The following is a description of a gene set: Top 100 ranked genes most specific to midbrain region of adult mouse brain. from publication Lein ES, Hawrylycz MJ, Ao N, Ayres M, Bensinger A, Bernard A, Boe AF, Boguski MS, Brockway KS, Byrnes EJ, Chen L, Chen L, Chen TM, Chin MC, Chong J, Crook BE, Czaplinska A, Dang CN, Datta S, Dee NR, Desaki AL, Desta T, Diep E, Dolbeare TA, Donelan MJ, Dong HW, Dougherty JG, Duncan BJ, Ebbert AJ, Eichele G, Estin LK, Faber C, Facer BA, Fields R, Fischer SR, Fliss TP, Frensley C, Gates SN, Glattfelder KJ, Halverson KR, Hart MR, Hohmann JG, Howell MP, Jeung DP, Johnson RA, Karr PT, Kawal R, Kidney JM, Knapik RH, Kuan CL, Lake JH, Laramee AR, Larsen KD, Lau C, Lemon TA, Liang AJ, Liu Y, Luong LT, Michaels J, Morgan JJ, Morgan RJ, Mortrud MT, Mosqueda NF, Ng LL, Ng R, Orta GJ, Overly CC, Pak TH, Parry SE, Pathak SD, Pearson OC, Puchalski RB, Riley ZL, Rockett HR, Rowland SA, Royall JJ, Ruiz MJ, Sarno NR, Schaffnit K, Shapovalova NV, Sivisay T, Slaughterbeck CR, Smith SC, Smith KA, Smith BI, Sodt AJ, Stewart NN, Stumpf KR, Sunkin SM, Sutram M, Tam A, Teemer CD, Thaller C, Thompson CL, Varnam LR, Visel A, Whitlock RM, Wohnoutka PE, Wolkey CK, Wong VY, Wood M, Yaylaoglu MB, Young RC, Youngstrom BL, Yuan XF, Zhang B, Zwingman TA, Jones AR (PMID 17151600) Molecular approaches to understanding the functional circuitry of the nervous system promise new insights into the relationship between genes, brain and behaviour. The cellular diversity of the brain necessitates a cellular resolution approach towards understanding the functional genomics of the nervous system. We describe here an anatomically comprehensive digital atlas containing the expression patterns of approximately genes in the adult mouse brain. Data were generated using automated high-throughput procedures for in situ hybridization and data acquisition, and are publicly accessible online. Newly developed image-based informatics tools allow global genome-scale structural analysis and cross-correlation, as well as identification of regionally enriched genes. Unbiased fine-resolution analysis has identified highly specific cellular markers as well as extensive evidence of cellular heterogeneity not evident in classical neuroanatomical atlases. This highly standardized atlas provides an open, primary data resource for a wide variety of further studies concerning brain organization and function. Mouse Gene Set: LEIN_MIDBRAIN_MARKERS studied in species Mus musculus, and this is the list of marker genes: Ddc, Ebf3, Ublcp1, Slc7a3, Ltbp3, Glra1, Ptgds, 4632415L05Rik, Ece2, Dennd1b, Kctd9, Slc4a2, Sema4g, Plp1, Itga10, 5031439G07Rik, Endod1 (NCBI Gene Id 97551), Itih3, Afap1, Dlk1, Baiap3, Col15a1, Tsc22d3, Agtr2, Sema3f, Prph, Slc17a6, Traip, Vat1l, Gpc5, Bnc2, Arhgef40, Zim1, Agt, Coprs, Kank4, Zfhx4, P2rx5, Slc8a3 (solute carrier family 8 (sodium/calcium exchanger), member 3), Zfhx3, Panx2, Hap1, Nsmaf, Klhl1, Vcf2, Clgn, Slc6a3, Ephb1, Opalin (oligodendrocytic myelin paranodal and inner loop protein), Gabrq, Cmklr2, Carmil3 (NCBI Gene Id 268747), Cers2, Qdpr, Dnm3, En1, Slc39a14, Maged2, Glra3, D830030K20Rik, Pcsk1n, Amy2a5, Eif5a2, Pou4f1, Crebl2, Aldoc, Pcolce2, Bcat1, Ankrd55 (ankyrin repeat domain 55), Steap2, Phlda3, Amigo2, B630019K06Rik, Glra4, Ttc39a, 4930555G01Rik, Mtmr2, Gje1, Tcf7l2, Pigt, Arrdc1, Htr2c, Cachd1, Gpr165, Glra2, Hmga1, Hars2, Cd83, Gfra1, Hjurp